Given this list of marker genes MIR30A, CD40, PLK2, ADAM17, FGFBP1, AKT1, MIR487B, ATP5F1B, HSPB1, JCAD, P2RX4, MIR23A, THBS1, VEGFC, MIR10A, NFE2L2, FGF18 (NCBI Gene Id 8817), MIR10B, MIR296, PRKD1, MIR221, MIR135B, MIR200A, ANGPT1, MIR101-1 (NCBI Gene Id 406893), FGFR1, ABL1, AMOT (angiomotin), ATP5F1A, MIR132, ETS1, GREM1, STAT5A, MIR27B, SIRT1, MIRLET7F1, GATA2, MIR143, MIR210, CIB1, SP1, MIR939, NOS3, VEGFA, TGFBR3, MIR126, PDGFB, MIR146A, AKT3, MIR499A, NRP1, FOXC2, MAPK14, HDAC7, FGF2, PIK3C2A, PRKCA, PDPK1, MAP2K3, ANXA1, HDAC9, PLCG1, PLG, MIR342, MIR150, RHOJ, TMSB4X, HMOX1, NUS1, MIR27A, SRPX2, HMGB1, ANGPT4, TGFB1, HIF1A, KDR, PRKD2, GAB1, PTGS2, MIR31, here is a description of the gene set: species: Homo sapiens Human Gene Set: GOBP_POSITIVE_REGULATION_OF_BLOOD_VESSEL_ENDOTHELIAL_CELL_MIGRATION Any process that activates or increases the frequency, rate or extent of the migration of the endothelial cells of blood vessels.